The following is a description of a gene set: Periorbital wrinkles Human Gene Set: HP_PERIORBITAL_WRINKLES studied in species Homo sapiens, and this is the list of marker genes: CDH11, EDAR, SMARCA2, EDARADD, EDA (ectodysplasin A)